Given this list of marker genes ATR, RPA1, ATRIP, RAD9B, RAD1, RAD9A, RPA2, HUS1, TOPBP1, RPA3, CHEK1, here is a description of the gene set: Human Gene Set: WP_ATR_SIGNALING species: Homo sapiens ATR signaling